Given this list of marker genes FGF20, SYT4, DRD2, CHRNA6, SNCG, DRD3, SNCA, GABBR1, CHRNA4, OPRK1, SYT11 (synaptotagmin 11), DTNBP1, NPY2R, KCNA2, PINK1, CHRNB2, HTR2A, SYT1, ABAT, GRM2, GDNF, PRKN, CXCL12, here is a description of the gene set: Any process that modulates the frequency, rate or extent of the regulated release of dopamine. species: Homo sapiens Human Gene Set: GOBP_REGULATION_OF_DOPAMINE_SECRETION